The following is a description of a gene set: Reactome Pathway: Loss of function of TP53 in cancer due to loss of tetramerization ability studied in species Homo sapiens The physiologically active form of TP53 is homotetramer, which represents a dimer of dimers, with the dimer considered to represent a transient intermediate. The tetramerization domain (TD) of TP53 localizes to the C-terminal region and involves amino acid residues 325-355 and is connected to the DNA binding domain (DBD) via a short unstructured region. The destabilizing effects of some of the DBD mutations in TP53 can only be observed in the context of the TP53 tetramer, but not in monomeric TP53. A number of nonsense and frameshift truncations result in mutant TP53 proteins that lack the tetramerization domain. In addition, several missense mutations affect the tetramerization domain, some of which, like R342P and L344P, have been shown to impede tetramerization. Oligomerization-defective TP53 TD mutants are considered to be complete loss-of-function mutants in terms of their transcriptional activity, without altered specificity, dominant-negative or gain-of-function effects. However, when overexpressed, some missense TD mutants of TP53 can form homotetramers and heterotetramers with the wild type TP53 which are partially functional and some extent of AS, DN and GOF effects may not be excluded for those mutants. In addition, the synthetic mutant p153(1-320) which consists of the first 320 amino acids and lacks the TD and the C-terminal domain (CTD), while unable to tetramerize, can form stacked oligomers at the recombinant target gene promoter and induce transcription at a low level. Stacked oligomers are formed through interactions that involve amino acid residues outside the TD, which are facilitated by the presence of a target DNA sequence. Recombinant TP53 that consists of amino acid residues 83-323 also predominantly exists as a monomer. part of: Loss of Function of TP53 in Cancer, and this is the list of marker genes: TP53